The following is a description of a gene set: Human Gene Set: SIG_CHEMOTAXIS Genes related to chemotaxis species: Homo sapiens, and this is the list of marker genes: PAK5, LIMK1, PAK2, INPPL1, CFL2, PPP1R13B, ITPR1, PDPK1, ARHGAP4, RHO, ROCK2, PIK3CG, BTK, PIK3CD, ITPR2 (NCBI Gene Id 3709), ARHGAP1, CFL1, SAG, ITPR3, RACGAP1, PIK3R5, PAK1, MYLK2, GDI1, ANGPTL2, MYLK, PTEN, PAK3, CDC42, ACTR2, WASL, ARHGEF11, GDI2, ROCK1, PAK6, PIK3R1, WASF1, ACTR3, AKT2, PAK4, AKT3, AKT1, PIK3CA, PITX2, RPS4X